Given this list of marker genes RABL2A (RAB, member of RAS oncogene family like 2A), E2F4, MYO5B, RFX2, RFX3, IFT81, CEP19, GPRASP2, DTNBP1, CEP192, RFX1, NSFL1C (NCBI Gene Id 55968), SNAPIN, TFDP2, BLOC1S1, STX5, GPR161, ACTN4, PTCH1, RILPL1, IFT172, VCPIP1, VCP, CIMAP3, SMO, DNM3, ARMCX5-GPRASP2, BLOC1S4 (biogenesis of lysosomal organelles complex 1 subunit 4), BLOC1S6, IFT74, IFT27, TUBG1, IFT25, ALMS1, here is a description of the gene set: Alstrom syndrome Human Gene Set: WP_ALSTROM_SYNDROME studied in species Homo sapiens